The following is a description of a gene set: studied in species Homo sapiens Human Gene Set: GSE12366_NAIVE_VS_MEMORY_BCELL_UP Sorted B cells using flow cytometry. CD19 selected B cells were sorted using flow cytometry. Genes up-regulated in comparison of naive B cells versus memory B cells. from publication Longo NS, Lugar PL, Yavuz S, Zhang W, Krijger PH, Russ DE, Jima DD, Dave SS, Grammer AC, Lipsky PE (PMID 19023113), and this is the list of marker genes: MMD, SATB1, PXT1, DDIT3, BATF2, KBTBD11, RFX4, TDRD12, ZNF418, TFF1 (trefoil factor 1), ALDH1A2-AS1, ABCB4, YBX3, SMIM10, OGFRL1 (NCBI Gene Id 79627), TENT5C, NFATC3, ZBTB39, FAM53B (NCBI Gene Id 9679), FNBP1L, FDFT1, MAGEE2, MYADM, C1orf53, RC3H1, ADGRG3, MIR600HG (MIR600 host gene), MCF2L, MAPK8IP1, GNB4, CD200, TPST1, CEPT1, TRMT61A, CEP85L, PPARD, STEAP1B, ZNF736, PTPRE, NCF1C, FCRL1, CD72, BACH2, ZNF488, MROH6, PLEKHA1, PMS2P1, SWT1, C16orf74, DIP2C, NSUN5, TENT5A, DGKD, RNASE6, SPTLC2, CD1A, PELI3, PNPLA7, RAPGEF6, ROR1, EDN1, TCL1A, DUSP6, CHPT1, CRY1, SPATA3-AS1, OLFM2, SLC39A8, WFDC21P, RBM5, GCA, RP9P, ADPRM, FOXP1-IT1, IGHM, NEIL1, PRKCE, LYL1, ADAMTSL2, STRBP, GPRC6A, PPP1R26-AS1, USF3, TFAM, DNAI3, PSME4, ZNF107, WDR19, SCN3B, CD79B, LIMS2, TM6SF1, ZNF629, CRIP3, NUDT12, XYLT1, FIG4, TRIM17, HSF5, HYCC1, DNASE1L3, S1PR1, KCNB2, FOXP1, RFTN1, AFF1 (NCBI Gene Id 83116), TTC39B, DDHD1, SLITRK3, TRAK1, CD83, ALDH1A2, LARS1, GK, TREML2, IGLV6-57, LINC01141, ZBTB10, NIBAN3, NMBR, FNBP4, RABEP2, PARP14, APLP2, XIRP1, BRS3, PEAK1, GALNT2, SLA, CEACAM7, HECTD4, FCER2, PKP4, CAMK2D, IL6, PCDH12, PTPRK, ROPN1, ABCB1, LINC00926, LINC02995, AP1B1, CCN6 (cellular communication network factor 6), P2RX1, ARHGEF5, BIRC3, GNG11, PLEKHA2, CYFIP2, SLC38A7, LAIR1, ARHGEF10, SLC8A2, PDE7B, TMEM71, ATP6V0A1, DTX1, LCTL, ZNF667-AS1, IPO13, IFI44, PSCA, IL4R, FBXW4P1, GIPC2, PCDH9 (NCBI Gene Id 57123), DPP6, ARPC4 (NCBI Gene Id 10093), KIAA0040, FPGS, MTMR1, GALNT6 (NCBI Gene Id 11226), SLC38A1, SH3BP2, GAS2L1, TSPAN13, ZCCHC18, DEF8, TBC1D22B, MEGF6 (NCBI Gene Id 1953), MARCHF3, ENC1, PLCD4, HIF3A, TCL1B, NEB, GATA2-AS1 (GATA2 antisense RNA 1), RGL2, EHD4, MSTN, SRBD1, CLIP3, SLC25A15, ZSCAN18, SLC25A53